Given this list of marker genes P4HTM (prolyl 4-hydroxylase, transmembrane), EGLN3, ALKBH3, DBH, PAM, P3H3, PHYH, PLOD3, P4HA2, OGFOD3, OGFOD2, EGLN2, P4HA1, PLOD2, PLOD1, P3H1, P4HA3, P3H2, OGFOD1, EGLN1, here is a description of the gene set: Binding to L-ascorbic acid, (2R)-2--4-hydroxy-5-oxo-2,5-dihydrofuran-3-olate; L-ascorbic acid is vitamin C and has co-factor and anti-oxidant activities in many species. Human Gene Set: GOMF_L_ASCORBIC_ACID_BINDING species: Homo sapiens